The following is a description of a gene set: species: Homo sapiens Human Gene Set: REACTOME_MODULATION_OF_HOST_RESPONSES_BY_IFN_STIMULATED_GENES Modulation of host responses by IFN-stimulated genes, and this is the list of marker genes: HSPA5, IFI6, FKBP5, EIF2AK3, RIGI, IFIH1, ARIH1, IKBKG, CHUK, UBA7, HERC5, IFI27, ISG15, TRIM25, IFI44L, UBE2L6, ATF6 (NCBI Gene Id 22926), IKBKB, IFI44